The following is a description of a gene set: studied in species Mus musculus from publication Vilimas T, Mascarenhas J, Palomero T, Mandal M, Buonamici S, Meng F, Thompson B, Spaulding C, Macaroun S, Alegre ML, Kee BL, Ferrando A, Miele L, Aifantis I (PMID 17173050) Genes up-regulated in bone marrow progenitors by constitutively active NOTCH1. Mouse Gene Set: VILIMAS_NOTCH1_TARGETS_UP T-cell acute lymphoblastic leukemia (T-ALL), unlike other ALL types, is only infrequently associated with chromosomal aberrations, but it was recently shown that most individuals with T-ALL carry activating mutations in the NOTCH1 gene. However, the signaling pathways and target genes responsible for Notch1-induced neoplastic transformation remain undefined. We report here that constitutively active Notch1 activates the NF-kappaB pathway transcriptionally and via the IkappaB kinase (IKK) complex, thereby causing increased expression of several well characterized target genes of NF-kappaB in bone marrow hematopoietic stem cells and progenitors. Our observations demonstrate that the NF-kappaB pathway is highly active in established human T-ALL and that inhibition of the pathway can efficiently restrict tumor growth both in vitro and in vivo. These findings identify NF-kappaB as one of the major mediators of Notch1-induced transformation and suggest that the NF-kappaB pathway is a potential target of future therapies of T-ALL., and this is the list of marker genes: Cd3g, Tnfrsf18, Trat1, Card11, Rag2, Rag1, Zap70, Icam1, Cd83, Cd74, Cd69, Egr2, Rras2, Nfkb2, Birc3, P2ry10 (purinergic receptor P2Y, G-protein coupled 10), Ctla4 (cytotoxic T-lymphocyte-associated protein 4), Ccr7, Dtx1, Ddr1 (discoidin domain receptor family, member 1), Cd7, Nfatc1 (nuclear factor of activated T cells, cytoplasmic, calcineurin dependent 1), Gzmd, Relb, Birc2, Id2, Junb, Cd80 (NCBI Gene Id 12519), Il10ra, Gata3, Lck, Nfkbia, Nrarp, Gzma, Hey1, Irf7, Egr1, Il12b, Lat, Thy1, Cx3cl1, Gzmc, Traf1, Ptcra, Ccl5, Cd2, Bcl2a1a, Tox, Cd3d, Cd86, Gzmb, Notch3, Cd28